Given this list of marker genes HIBCH, H4C8, BAHCC1, IL12RB2, PNPLA2, TEKT2, DNAL4, RBBP9, STAB1, IKBKB, PLK2, SIVA1, ABHD3, TOP6BL, CT55, H1-6, CDH16, PSAT1, MRC1, EGR3, DIO3, PTDSS2, CDH17, CCL24, CRISP3, EXOSC1 (NCBI Gene Id 51013), RGN, PTGS1, EHMT1, NAT8, UNC5C, IL37, CCT2, CLC, NPHP1, GSDMB, FETUB, AQR, PRKAA1, MRPS35, TRO, TRIM2, HSPH1 (heat shock protein family H (Hsp110) member 1), PSMA1, C17orf75, MAP2, GOLGA1, GRM1, ZNF665, ENSG00000274253, FXYD2, DFFB, HRH3, TEK, RAG2, EPRS1, MRM3, SRGAP2, DAAM1, IFT122, CRYGA, FAM110D, HIC2, CCDC40 (coiled-coil domain 40 molecular ruler complex subunit), ANGPT2, PKN1, TMCO6, MACROH2A1, PAX6, PDE12, ARPP21, TBC1D22B, TLL2, TUBB6, GCK, RPS2, JAK3, WRNIP1, TMEM104, PBXIP1, KCNK2, MACROD1 (mono-ADP ribosylhydrolase 1), ELOB, FHOD3, RIMBP2, CPS1, MED8, GAD1, FAM215A, RIMS3, RTF2, KCNK13, TMEM70, CCL13, PFKFB4, PTGER3, H3C8, PRSS12, CTNNAL1, HTATSF1, SOX18, NME3, SLC22A6, CACNA2D1, GCG, PPM1E, ZCWPW1, C14orf93, ADK, SBSPON, HOXA7, SIT1 (signaling threshold regulating transmembrane adaptor 1), KNL1 (kinetochore scaffold 1), GS1-600G8.3, SLC7A10, PTPN11, RNASET2, STEAP4, GPC1, FEZF2, ZNF528 (NCBI Gene Id 84436), LINC01587, LHFPL6, SRRM2, H3C2, AGGF1, SELE, GUSBP11, HEATR6, RAI2, NAGPA, SLC25A14, PGLYRP1, KPNA3, SMAGP, CACNA1G, RIT2, ZSCAN18, IRF3, CDKN2C, OGFOD2, TWSG1, AKAP5, KLHL26, TMEM30B, TEFM, MYL3, MPIG6B, KCNK15, EFL1, ASPSCR1, ACADSB, ZNF443, SNAP91, ABI3BP, SMAD6, SDK2 (sidekick cell adhesion molecule 2), IL6ST, COQ8B, PMCH, CCN4, AKR1C3, TRDV2, ANKS1B, CHRNB1, DNAJC22, UBL3, TTC27, LINC00837, EYA3, MINDY2, GUCA2B, ICAM4, HLA-DRB6, COL1A2 (collagen type I alpha 2 chain), LRP12, ZKSCAN7, EHD3, CEACAM21, MRE11, CLN5, ST3GAL6, UGT2B28 (NCBI Gene Id 54490), HOXD9, RPS6KB1, IFNW1, SSX7, TKFC, ACSL6, ZHX3, ADAM29, MTNR1B, KLC2, ERI3, CMC4, BPI, APOE, here is a description of the gene set: Genes down-regulated in HEK293 cells expressing: wildtype NOD2 versus mutant NOD2. NOD2 is an intracellular receptor for the bacterial cell wall component muramyl dipeptide (MDP) and variants of NOD2 are associated with chronic inflammatory diseases of barrier organs e.g. Crohn disease, asthma and atopic eczema. It is known that activation of NOD2 induces a variety of inflammatory and antibacterial factors. The exact transcriptomal signatures that define the cellular programs downstream of NOD2 activation and the influence of the Crohn-associated variant L1007fsinsC are yet to be defined. To describe the MDP-induced activation program, we analyzed the transcriptomal reactions of isogenic HEK293 cells expressing NOD2wt or NOD2L1007fsinsC to stimulation with MDP. Importantly, a clear loss-of-function could be observed in the cells carrying the Crohn-associated variant L1007fsinsC, while the NOD2wt cells showed differential regulation of growth factors, chemokines and several antagonists of NF-κB, e.g. TNFAIP3 (A20) and IER3. Human Gene Set: GSE22611_NOD2_VS_MUTANT_NOD2_TRANSDUCED_HEK293T_CELL_DN species: Homo sapiens from publication Billmann-Born S, Till A, Arlt A, Lipinski S, Sina C, Latiano A, Annese V, Häsler R, Kerick M, Manke T, Seegert D, Hanidu A, Schäfer H, van Heel D, Li J, Schreiber S, Rosenstiel P (PMID 21335489)